Given this list of marker genes HCN2, TGFB1, PARK7, SCNN1B, RDH11, ADH5, AKR1B10, ADH4, SCNN1D, ESD, AKR1A1, SCNN1A, ALDH1A1, RDH12, AIFM1 (apoptosis inducing factor mitochondria associated 1), SCNN1G, SGK1, here is a description of the gene set: studied in species Homo sapiens Human Gene Set: GOBP_CELLULAR_RESPONSE_TO_ALDEHYDE Any process that results in a change in state or activity of a cell (in terms of movement, secretion, enzyme production, gene expression, etc.) as a result of an aldehyde stimulus.